Given this list of marker genes CCNH, DR1 (NCBI Gene Id 1810), TAF11L6, TBP, TAF11L10, TAF8, TAF4, GTF2E1, TAF11L13, SNAPC2, GTF2H3, GTF2F1, TAF11, TAF11L14, TAF10, GTF2E2, TAF2, TAF11L4, TAF11L9, PAAF1, TAF4B, TAF1L, DRAP1, TAF11L11, TAF11L3, TAF3, PRRX1, TAF1, SNAPC1, GTF2B, TAF11L8, TAF9B, TAF5, GTF2H4, GTF2A2 (general transcription factor IIA subunit 2), BRF2, GTF2F2, TAF9, TAF12, TAF6, TAF11L7, TAF11L12, SNAPC4, TAF7L, TAF7, GTF2A1, GTF2H2, TBPL2, TAF11L2, TAF13, TAF6L, SNAPC5, TBPL1, here is a description of the gene set: Human Gene Set: GOMF_RNA_POLYMERASE_II_GENERAL_TRANSCRIPTION_INITIATION_FACTOR_ACTIVITY species: Homo sapiens A general transcription initiation factor activity that contributes to transcription start site selection and transcription initiation of genes transcribed by RNA polymerase II. The general transcription factors for RNA polymerase II include TFIIB, TFIID, TFIIE, TFIIF, TFIIH and TATA-binding protein (TBP). In most species, RNA polymerase II transcribes all messenger RNAs (mRNAs), most untranslated regulatory RNAs, the majority of the snoRNAs, four of the five snRNAs (U1, U2, U4, and U5), and other small noncoding RNAs. For some small RNAs there is variability between species as to whether it is transcribed by RNA polymerase II or RNA polymerase III. However there are also rare exceptions, such as Trypanosoma brucei, where RNA polymerase I transcribes certain mRNAs in addition to its normal role in rRNA transcription.